The following is a description of a gene set: species: Mus musculus Mouse Gene Set: GOBP_NEURAL_PLATE_PATTERN_SPECIFICATION The developmental process that results in the creation of defined areas or spaces within the neural plate to which cells respond and eventually are instructed to differentiate., and this is the list of marker genes: Ptch1, Nog (noggin), Celsr2, Ofd1, Tbx18, Ssbp3, Fuz, C2cd3, Bmpr1a